Given this list of marker genes ECHS1, HADHB, HADHA, ACADL, ACADS, ACADSB, ACAA2, HADH, ACADM, ACADVL, ACAT1, here is a description of the gene set: Pathway Definition from KEGG: Acyl-CoA(n) -- (ACADM,ACADL,ACADVL,ACADS,ACADSB) >> ((ECHS1+HADH),HADHA) >> (ACAA2,HADHB,ACAT1) -> Acyl-CoA(n-2) Human Gene Set: KEGG_MEDICUS_REFERENCE_BETA_OXIDATION beta-Oxidation. Pathway ID: N00804. Pathway type: Reference. Pathway class: nt06020 beta-Oxidation in mitochondria. species: Homo sapiens